The following is a description of a gene set: studied in species Mus musculus Any process that modulates the frequency, rate or extent of gluconeogenesis, the formation of glucose from noncarbohydrate precursors, such as pyruvate, amino acids and glycerol. Mouse Gene Set: GOBP_REGULATION_OF_GLUCONEOGENESIS, and this is the list of marker genes: Gpt, Serpina12, Dgat2, Mup1, Xpc, Gck, Dgkq, Mup2, Slc35b4, Tcf7l2, Lep, Supt20, Erfe, Mup5, Zfp692, Ppara, Sesn2, Mst1, Clk2, Sirt7, Lepr (leptin receptor), Kat2b, Acadm, C1qtnf3, Foxo1, Kat2a, Cyp2j6, Ep300, Pfkfb1, Mup11, Usp7, Ogt, Mup4, Adipoq, Ranbp2, Obp2a, Sirt1, Fbp1, C1qtnf12, Gcg, Nr3c1, Il6, Sirt6 (NCBI Gene Id 72769), Mtcl2, Pdk2, Sik1, Pgp, Hnf4a, Gnmt, Ddb1, Nln, Ppp4r3a, Nnmt, Stk11, Mup3, Wdr5, Arpp19, Hif1a, Prkag2, Prkag1, Cry1, Prkag3, Oprm1 (opioid receptor, mu 1), Ppp4r3b, Ptpn2 (protein tyrosine phosphatase, non-receptor type 2), Prkaca